Given this list of marker genes HCK, PHIP, MELTF, KRT8, ANO7, BCAM, ADGRG6, SKAP2, BRD4, KCTD12, IFI6, MYO1B, TMEM74B (NCBI Gene Id 55321), GABRP, HTR3E, RASSF6, PBXIP1, FGFR4, TAMALIN, GNG13, ANKRD30BL, RASSF7, SOX4, PIK3R5, BMX, CRIP1, TMEM87A, PTPN18, SERPINA1, TMEM176A, AOC1, SH2D6, MATK, ALOX12B (NCBI Gene Id 242), ACTN1, ITPR2, MT2A, SPIB, CLMN, LUC7L3, ZDHHC8BP, ALOX5AP (NCBI Gene Id 241), MARCKSL1, TPM1, HPGDS, GNAI2, FYB1, SIGIRR, MTSS1, AZGP1 (NCBI Gene Id 90053), SNRNP27, ADH6, CHD9, KRT18, ALOX5, IRAG2, TRPM5, PLCG2, PIK3CG (phosphatidylinositol-4,5-bisphosphate 3-kinase catalytic subunit gamma), TMEM176B, B4GALNT4, GSN, SEPTIN2, PSTPIP2, ZFHX3, CD24, ID2, VIPR1, PTGS1, SOX9, CCSER1, FARP2, KMT2C, MT1G, AVIL, ATP2A3, FURIN, IL17RB, CORO2B, POU2F3, KLK13, here is a description of the gene set: Human Gene Set: BUSSLINGER_DUODENAL_TUFT_CELLS from publication Busslinger GA, Weusten BLA, Bogte A, Begthel H, Brosens LAA, Clevers H (PMID 33691112) species: Homo sapiens